The following is a description of a gene set: studied in species Homo sapiens Gene expression from WT and NFAT5 KO primary macrophage cultures. from publication Buxadé M, Lunazzi G, Minguillón J, Iborra S, Berga-Bolaños R, Del Val M, Aramburu J, López-Rodríguez C (PMID 22312110) Human Gene Set: GSE26343_WT_VS_NFAT5_KO_MACROPHAGE_DN Genes down-regulated in bone marrow-derived macrophages: wildtype versus NFAT5 knockout., and this is the list of marker genes: ZNFX1, CDYL2 (NCBI Gene Id 124359), BCOR, CD200, ATP11A, DKKL1, CLEC6A, SYK, GTF2B, ADORA2B, B4GALT5, FAM133B, GPR132, KIT, NCOA7, ZNF691, RASSF8, IRF9, CX3CR1, IL15, STBD1, PRDM1, MMP13, ST3GAL1, ADAM17, RNF2, UBXN2A, CSF2, TENT5C, MAP3K8, RIPK2, SPRED1, ANKRD28, PTPN1, IQSEC1, GRAMD1B, SBDS, CD82, UBE2F, RHOF, CSF3, HBEGF, PTPN2, SLC15A2, EBI3 (Epstein-Barr virus induced 3), GBP4 (guanylate binding protein 4), NRP2, RELA, RPS6KA2, EDEM1, CTTNBP2NL, GPR183, CASP4, SLC22A4, AGAP1, GPR65, CA13, BCL2L14, TENT4A, UBTD2, RFX5, IRF7, SLC39A4, TUBB6, PDE4DIP, RAPGEF5, DENND11, SUCO (NCBI Gene Id 51430), BATF, IFNAR1, SLC34A3, TGIF1, RNF19A, DUSP5, SPATA13, ITGB8, TMEM176B, IKBKE, MAB21L3, PROCR, ZNF513, UBE2N, OASL, PLEKHO2, SETDB2, OPTN, RAB12, SLAMF8, EPOP, ACP5, EFNA2, GHITM, MARCHF5, NCOA5, ST6GALNAC4, SAA1, CASS4, ANKRD17, SERPINB2, CLCF1, PNRC1, BCL2L1, RRAD, CD70, RHBDF2, SLAMF7, EIF6, RASAL1, FAS, MKNK2, SLC15A3, TANK, LYNX1 (Ly6/neurotoxin 1, NCBI Gene Id 66004), HVCN1, MAPRE2, EEA1, CALCRL, SLC2A1, CDK17, ZMIZ2, MARCKS, PDPN, LAD1, RAMP3, TNFRSF1B, DAXX, CCL5, NFE2L2, REST, SLC7A2, TJP2, SUB1, HLA-DRB1, PAPSS2, NR1H3, MREG, OSGIN2, PLEKHF1, GBP2, UBE2E3, GIMAP6, STK40, EXOC3L4, SLC11A2, RASA2, KLF10, GNA13, ARG2 (arginase 2), IRAK3 (NCBI Gene Id 11213), RNF34, KDM1B, SYNPO2, AGPAT4, JUNB, DUSP16, MYO1G, MAMLD1, TMEM267, TNFAIP2, TRAF3, SWAP70, DENND4A, SH3BP2, PTPN23, VAV3, DUSP14, NIPAL1, CLCN7, ADM, IL10, SUGT1, GRHL1, SGMS2, FOXP4, ACTN1, IDI1, ADORA2A, ERO1A, FCER2, NAMPT, PPP1R11, RNF149, SPECC1, ARL5B, FBRS, GK, RCSD1 (NCBI Gene Id 92241), HSPA1B, SEL1L, TMEM120B, NR4A3, PCDH7, N4BP1, CDC14A, CCL17 (NCBI Gene Id 6361), SOCS3, DAPP1, NOTUM, PSME1, TNFAIP8L1